Given this list of marker genes MYT1L, DHPS, ASXL2, DPYSL5, MRPS16, FBXL4, CDC42BPB, here is a description of the gene set: studied in species Homo sapiens Abnormal fetal central nervous system morphology An anomalous structural finding of the fetal central nervous system. Terms in this subhierarchy are restricted to findings that can only be observed in the prenatal period. Other HPO terms can also be used to describe fetal phenotypes. Human Gene Set: HP_ABNORMAL_FETAL_CENTRAL_NERVOUS_SYSTEM_MORPHOLOGY